Given this list of marker genes Alas1, Rp1, Vmn2r43, Irx2, Srsf1, Dmrtc1a, Pdha1, Fam193a, Ccnyl1, Timm21, Ppp3cb, Prdm2, Cnot7, Gxylt1, Bdnf, Phex, Mms19, Lrp11, Epb41l3, Tm9sf3, Zfp462, Pakap, Ap3s1, Slc18a2, Ddah1, Cdh6, Nrdc, Bmi1, Stap1, Inpp4b, Cflar, Zfp704, Fkbp1b, Tc2n, Gdap2, Kcnj6, Hbegf, Fosb, Laptm4a, Magt1, Ankrd46, Nipa2, Esf1, Ugt1a6b (UDP glucuronosyltransferase 1 family, polypeptide A6B), Adhfe1, Kcne1, Clxn, Pcdh17, Wif1, Vps26b, Slc6a20b (NCBI Gene Id 22599), Ugt8a, Rpgr, Katnbl1, Adnp, Nbr1, Ablim3, Nxpe2, here is a description of the gene set: Genes predicted to be targets of miRBase v22 microRNA mmu_miR_3086_5p in miRDB v6.0 with MirTarget v4 prediction scores > 80 (high confidence targets). studied in species Mus musculus Mouse Gene Set: MIR_3086_5P from publication Chen Y, Wang X (PMID 31504780)